Given this list of marker genes Ppat, Gart, Impdh2, Impdh1, Adsl, Pfas, Atic, Paics, here is a description of the gene set: species: Mus musculus The chemical reactions and pathways involving XMP, xanthosine monophosphate. Mouse Gene Set: GOBP_XMP_METABOLIC_PROCESS